The following is a description of a gene set: species: Mus musculus Any process that increases the rate, frequency or extent of sequestering of triglyceride. Triglyceride sequestration is the process of binding or confining any triester of glycerol such that it is separated from other components of a biological system. Mouse Gene Set: GOBP_POSITIVE_REGULATION_OF_TRIGLYCERIDE_STORAGE, and this is the list of marker genes: Apoc4 (NCBI Gene Id 11425), Plin5, Plin2, Lpl, Osbpl11, Plin3 (NCBI Gene Id 66905)